Given this list of marker genes Ptbp1, Srsf12, Myod1, Rbfox1, Rbm47, Ddx17, Rbm7, Rbm24, Sap18b, Zbtb7a, Rnps1, Nova2, Dyrk1a, Srsf8, Celf3, Rbm15, Puf60, Rbmx, Celf5, Nsrp1, Arb2a (NCBI Gene Id 72538), Hnrnpl, Rbm8a, Smu1, Rbmxl1, Celf6, Rbm5, Rest, Wtap, Magoh, Khdrbs3, Sap18, Eif4a3, Ythdc1, Malat1 (NCBI Gene Id 77292), Thrap3, Srrm4, Mbnl1, Rbpms2, Celf1, Fmr1, Rbpms, Arglu1, Rbm4, Rbm25, Rbm20 (NCBI Gene Id 73713), Rbm11, Celf4, Hnrnpu, Rbfox3, Tia1, Khdrbs2 (KH domain containing, RNA binding, signal transduction associated 2), Srsf2, Rbfox2, Khdrbs1, Srsf6, Nova1, Mbnl2, Ddx5, Thumpd2, Tra2b, Celf2, Rbm8a2, Rbm15b, here is a description of the gene set: Any process that modulates the frequency, rate or extent of alternative splicing of nuclear mRNAs. species: Mus musculus Mouse Gene Set: GOBP_REGULATION_OF_ALTERNATIVE_MRNA_SPLICING_VIA_SPLICEOSOME